Given this list of marker genes Pnpla8, Selenoi, Plaat3, Plb1, Etnk1, Abhd4, Plaat5, Chkb, Pla2g10, Chka, Lpin1, Etnk2 (ethanolamine kinase 2), Alox15, Pla2g15, Cept1, Pla2g6, Pla2g2a, Mfsd2a, Naaa, Lipc, Plaat1, Pcyt2, Napepld, Pisd, Pla2g4e, Slc27a1, Pla2g2d, Pla2g3, here is a description of the gene set: studied in species Mus musculus Mouse Gene Set: GOBP_PHOSPHATIDYLETHANOLAMINE_METABOLIC_PROCESS The chemical reactions and pathways involving phosphatidylethanolamine, any of a class of glycerophospholipids in which a phosphatidyl group is esterified to the hydroxyl group of ethanolamine. It is a major structural phospholipid in mammalian systems. It tends to be more abundant than phosphatidylcholine in the internal membranes of the cell and is an abundant component of prokaryotic membranes.